The following is a description of a gene set: Genes upregulated in subsets of cells of a given type within various tumors from publication Gavish A, Tyler M, Greenwald AC, Hoefflin R, Simkin D, Tschernichovsky R, Galili Darnell N, Somech E, Barbolin C, Antman T, Kovarsky D, Barrett T, Gonzalez Castro LN, Halder D, Chanoch-Myers R, Laffy J, Mints M, Wider A, Tal R, Spitzer A, Hara T, Raitses-Gurevich M, Stossel C, Golan T, Tirosh A, Suvà ML, Puram SV, Tirosh I (PMID 37258682) Human Gene Set: GAVISH_3CA_METAPROGRAM_EPITHELIAL_RESPIRATION studied in species Homo sapiens In this study, an extensive analysis was conducted to define meta-programs (MPs) capturing intra-tumor heterogeneity across a spectrum of tumor types. The approach utilized non-negative matrix factorization (NMF) to analyze each cell type separately within individual tumor samples. This involved the analysis of malignant cells, macrophages, fibroblasts, endothelial cells, epithelial cells, T-cells, and B-cells. NMF was executed with varying parameter values (K=4, 5, 6, 7, 8, 9), thereby generating 39 programs for each cell type per sample. Each NMF program was summarized by the top genes based on NMF coefficients.\nRobust MPs were then delineated for each cell type using a set of stringent criteria, including recurrence within the same tumor, similarity to programs in other tumors, and non-redundancy within a tumor. Subsequently, these robust NMF programs were clustered (per cell type) based on Jaccard similarity, leading to the identification of MPs associated with each cell type.\nTo enhance the quality of the MPs, a refinement steps were undertaken, involving the removal of MPs suspected of reflecting low-quality data (with an overrepresentation of ribosomal proteins or mitochondrial-encoded genes), single-study inclusion, or similarity to miss-annotated cell types., and this is the list of marker genes: COX8A, CYCS, GSTP1, ATP5PO, ATP1B1, SLC25A4, CKB, HSPA2, IDH2, NDUFA5, SLC25A5, ATP5MC1, ALDOA, ENO1, NUDT4, CHCHD10, MPC1, NDUFS6, LDHB, TMEM52B, PRDX3, FXYD2, COX5B, ATP5F1B, PRDX2, DEFB1, COX7B, ATP5PD, ATP5F1C, ATP5MC3, UQCRH (ubiquinol-cytochrome c reductase hinge protein), MRPS6, UCHL1, ATP5MK, COX5A, NDUFB1, PEBP1, BEX3, DUSP9, CBR1 (NCBI Gene Id 873), COX6B1, UMOD, ATP5MG, KNG1, ATP5PF, CYSTM1, NDUFA1, CD24, S100A6, GSTM3